The following is a description of a gene set: An eating behavior process whereby detection of a dietary excess results in a decrease in intake of nutrients. species: Mus musculus Mouse Gene Set: GOBP_REDUCTION_OF_FOOD_INTAKE_IN_RESPONSE_TO_DIETARY_EXCESS, and this is the list of marker genes: Guca2b, Rmi1, Prlh, Gdf15, Col6a1 (NCBI Gene Id 12833), Gfral, Cntn2, Nmur2, Cckar, C1qtnf4